Given this list of marker genes ODAD1, DNAH17, NME8, DNAI2, DNAH9, CCDC103, CFAP70, DNAH5, DNAH8, DNAI1, DNAL1, here is a description of the gene set: Human Gene Set: GOCC_OUTER_DYNEIN_ARM studied in species Homo sapiens Outer arm structure present on the outer doublet microtubules of ciliary and flagellar axonemes. Outer dynein arms contain 2-3 heavy chains, two or more intermediate chains and a cluster of 4-8 light chains. Inner and outer dynein arms have different functions in the generation of microtubule-based motility.